Given this list of marker genes JAK3, IL2RG, NHP2, ZAP70, PNP, ADA, DCLRE1C, IL7R, RAG1, RAG2, here is a description of the gene set: Recurrent opportunistic infections Human Gene Set: HP_RECURRENT_OPPORTUNISTIC_INFECTIONS studied in species Homo sapiens Increased susceptibility to opportunistic infections, as manifested by recurrent episodes of infection by opportunistic agents, i.e., by microorganisms that do not usually cause disease in a healthy host, but are able to infect a host with a compromised immune system.